Given this list of marker genes CCL17, PSMB7, UBC, PSMD13, FBXW11, UBA52, PSMD2, PSMB2, PSMA1, PSMD7, BTRC, PSMD14, PSMB4, PSMA6, PSMA4, PSMC3, UBE2M, MAP3K14, PSMB5, UBB, PSMB6, PSMD1, PSMD8, PSMC5, RELB, PSMD6, ADRM1, PSMD11, PSMB3, CUL1, RPS27A, PSMA3, PSMC1, RELA, PSMD12, UBA3, CHUK, SEM1, CCL22, PSMC4, PSMA5, PSMD3, PSMC6, PSMA7, PSMB1, PSMA2, PSMC2, SKP1, NFKB2, here is a description of the gene set: species: Homo sapiens Human Gene Set: REACTOME_DECTIN_1_MEDIATED_NONCANONICAL_NF_KB_SIGNALING Dectin-1 mediated noncanonical NF-kB signaling